Given this list of marker genes Vps16, Tgfbrap1, Vps8, Vps33b, Vps11, Vps33a, Vps18, here is a description of the gene set: A multimeric protein complex that acts as an endosomal tethering complex (CORVET = class C core vacuole/endosome tethering) by cooperating with Rab GTPases to capture endosomal vesicles and trap them prior to the action of SNAREs; the complex is involved in endo-lysosomal biogenesis and required for transport between endosome and vacuole. The Saccharomyces cerevisiae complex contains Vps8p, Vps3p, Pep5p, Vps16p, Pep3p, and Vps33p. Mouse Gene Set: GOCC_CORVET_COMPLEX species: Mus musculus